The following is a description of a gene set: studied in species Mus musculus Negative regulation of MAPK pathway Mouse Gene Set: REACTOME_NEGATIVE_REGULATION_OF_MAPK_PATHWAY, and this is the list of marker genes: Ywhab, Uba52rt, Mapk12, Rps27a, Hras, Ppp2ca, Pebp1, Map2k2, Dusp9, Ksr1, Ppp2r1a, Ppp2r5b, Braf, Ppp2r5e, Dusp2, Uba52, Ppp2r5c, Ppp5c, Mapk1, Ptpn3, Mapk3, Dusp6, Ppp2r1b, Ppp2r5a, Ppp2cb, Ubc, Dusp4, Map2k1, Araf, Dusp1, Dusp5, Brap, Ptpn7, Ppp2r5d, Ubb, Mark3, Raf1, Kras, Dusp16, Dusp7, Dusp10, Dusp8, Paqr3